Given this list of marker genes ADD3, MAP1B, SNCA, MLST8, ESAM, DMTN, PLEKHG2, SPTBN4, RPS3, CCL21, ARHGAP18, CDC42EP4, HCK, CORO1A, CAPZB, CKAP5, SSH3, SLAIN1 (SLAIN motif family member 1), ADD2, RASA1, ALOX15, PSRC1, NCKAP1, GSN, PRKCD, ARF6, TPPP, TMSB4X, GIT1 (GIT ArfGAP 1), KANK4, NCK1, MAPRE1, NPHS1, KANK2, PDE4DIP, CAPZA2, GRB2, EML2, HSP90AA1, HSPA1A (NCBI Gene Id 3303), BAG4, PYCARD, RICTOR, FCHSD2, HAUS6, CLASP2, NUMA1, CLIP1, TENM1, TRIOBP, TTBK1, SPTBN2, DYRK1A, CAV3, CDC42EP1, TPPP3, ARPC2, PPP2CA, HAUS4, CRACD, SSH2, TWF2, MAPRE3, DRG1, BAIAP2, LATS1, CDC42EP5, SLAIN2, ANKRD53, DAAM2, TBCD, RAC1, HSPA1B, PRUNE1, ARHGAP40, CCL26, HAX1, ARHGEF7, CLIP3, AVIL, PFN2, FER, SSH1, TOGARAM1, KANK3, LMOD1, FLII, CARMIL2, INPP5J, MECP2, SPTA1, DCTN1, FCHSD1 (FCH and double SH3 domains 1), CYFIP1, OCLN, CDC42EP3, BIN1, CCL24, KIRREL1, SPTAN1, LMOD3 (leiomodin 3), MAPT, BAIAP2L2, CFL1, VIL1, ELN, PAK1, HIP1R, PRKCE (protein kinase C epsilon), NME7, ABITRAM, C15orf62, TUBB4A, PINK1, SNX9, CDC42EP2, TMOD2, AKAP9, SVIL, RDX, ARHGAP28, PTK2B, PPP2CB, ARPC3, CLASP1, CCL11, ADD1, CCR7, CARMIL1, CYRIA, CTTN, SLC39A12, FES, TMOD1, ARL2, MTPN, TPPP2, FKBP4, NCK2, SKA1, VILL, EPS8, CDH5, KANK1, ARPC5L, MIR214, BBS4, MTOR, HAUS8, CDK5R1, MET, BAIAP2L1, COTL1, WASHC2C, SCIN, STMN2, NAV3, HAUS5, LMOD2, CSF3, PAK3, CDKN1B (NCBI Gene Id 1027), CAPZA1, CAMSAP2, CYRIB, CAMSAP1, HAUS2, SLIT2, ABL1, VASP, CYFIP2, HCLS1, MYADM, ARFGEF1, HAUS3, CAPZA3, CDK5RAP2, HAUS7, NCKAP1L, ASB2, TMOD4, SPTBN1, TMOD3, CAPG, HAUS1, TWF1, ARPC5, MAP2, GBA2, DLG1, PFN1, PREX1, AMBRA1, CAMSAP3, PFN3 (NCBI Gene Id 345456), EVL, STMN1, KIF21A, MKKS, SPTB, PIK3R2, SPTBN5, here is a description of the gene set: Any process that modulates the frequency, rate or extent of the process of creating protein polymers. Human Gene Set: GOBP_REGULATION_OF_PROTEIN_POLYMERIZATION studied in species Homo sapiens